The following is a description of a gene set: The chemical reactions and pathways involving pigment, any general or particular coloring matter in living organisms, e.g. melanin. Mouse Gene Set: GOBP_PIGMENT_METABOLIC_PROCESS studied in species Mus musculus, and this is the list of marker genes: Iba57, Urod, Myo5a, Lct, Ddt, Hmox1, Dct, Alas2, Rpe65, Fxn, Tyrp1, Zeb2, Cited1, Tbx2, Slc45a2, Wnt5a, Slc48a1, Abcc2, Mc1r, Blvra, Bcl2 (NCBI Gene Id 98734), Mfsd12 (major facilitator superfamily domain containing 12), Ireb2, Vhl, Atp5if1, Slc6a9, Cpox, Cox15, Fech (ferrochelatase), Trpc1, Atp7a, Hmox2, Slc11a2, Slc7a11, Ppox, Bdh2, Hmbs, Cyp2a5, Slco1b2, Rapgef2, Cyb5r4, Snx3, Blvrb, Hebp1, Slc24a5, Abcb10, Cox10, Grk3, Tmem14c, Alas1, Ctns, Alad, Cdh3, Pmel, Pgrmc1, Rab38, Gipc1, Hnf1a (NCBI Gene Id 21405), a, Opn3, Tmem14a (NCBI Gene Id 96919), Ugt1a1, Appl1, Abcb7, Srrd, Tyr, Slco1a6, Sox2, Abcb6, Slc25a39 (NCBI Gene Id 68066), Uros, Oca2 (NCBI Gene Id 18431), Hpx